The following is a description of a gene set: Any process in which a protein is transported to, or maintained at, the phagophore assembly site (PAS). studied in species Mus musculus Mouse Gene Set: GOBP_PROTEIN_LOCALIZATION_TO_PHAGOPHORE_ASSEMBLY_SITE, and this is the list of marker genes: Atg16l1, Lrba, Atg9b, Arfip2, Mfn2 (NCBI Gene Id 170731), Atg4d, Atg4b (NCBI Gene Id 98652), Wdr45, Atg9a, Wipi1, Atg13, Stx17, Wipi2 (NCBI Gene Id 76581), Pik3c3, Wdr45b, Pacs2